Given this list of marker genes NFKBIA, S100A8, FGG, TRAF3, TLR6 (NCBI Gene Id 10333), TICAM1, NFKB2, TLR2, S100A1, NFKB1, BTK, IKBKG, CD36, CD14, TLR7, IKBKB, TLR1, UNC93B1, FGB, FGA, TLR10, TLR5, IRAK4, TIRAP, HMGB1, TLR3, MYD88, RELA (NCBI Gene Id 5970), S100A9, TLR4, CHUK, LY96, here is a description of the gene set: Diseases of Immune System studied in species Homo sapiens Human Gene Set: REACTOME_DISEASES_OF_IMMUNE_SYSTEM